The following is a description of a gene set: Mouse Gene Set: REACTOME_DECTIN_1_MEDIATED_NONCANONICAL_NF_KB_SIGNALING Dectin-1 mediated noncanonical NF-kB signaling studied in species Mus musculus, and this is the list of marker genes: Psmc2, Psmd1, Psma1, Psmb1, Psmb6, Psmc6, Psmb2, Psma4, Rps27a, Psmd14, Uba3, Skp1, Psma2, Ubc, Nfkb2, Psmd2, Psmc3, Psmb4, Psma5 (proteasome subunit alpha 5), Ubb, Chuk, Psmb5, Psma6, Uba52rt, Map3k14, Psmc4, Fbxw11, Cul1, Psma7, Ube2m, Psmc1, Psmb3, Psmd11, Psmc5, Psmd6, Adrm1, Relb, Psmd13, Psmd7, Psmb7, Psmd8, Psma3, Uba52, Psmd12 (NCBI Gene Id 66997), Psmd3